The following is a description of a gene set: species: Homo sapiens Any process that results in a change in state or activity of a cell or an organism (in terms of movement, secretion, enzyme production, gene expression, etc.) as a result of an anesthetic stimulus. An anesthetic is a substance that causes loss of feeling, awareness, or sensation. Human Gene Set: GOBP_RESPONSE_TO_ANESTHETIC, and this is the list of marker genes: SLC1A1, CASP3, S100B, CASP8, CASP9, GABRB3